Given this list of marker genes Cyp2d26, Cyp2b23, Cyp4x1, Cyp2d10, Cyp2d9, Cyp2b10 (NCBI Gene Id 13091), Cyp2d40 (NCBI Gene Id 71754, cytochrome P450, family 2, subfamily d, polypeptide 40), Cyp2d22, Cyp2d12 (NCBI Gene Id 380997), Cyp2b19, Cyp2d34, Cyp2d11, Cyp2b9, Cyp2b13, here is a description of the gene set: Mouse Gene Set: GOMF_ANANDAMIDE_EPOXIDASE_ACTIVITY studied in species Mus musculus Catalysis of the epoxidation of double bonds of the arachidonoyl moiety of anandamide.